Given this list of marker genes KCTD12, TJP3, LPXN, SHOX2, MAEA, RBFOX2, MBTPS2, SMTN, LTB4R, CXCL11, SCGB1A1, TIMP1, LPA, F3, BAP1, USP46, H4C2, SDHC, ABCD1, ZFP69B, SUSD5, ATRNL1, TBCD, DCBLD2, WASHC4, TOM1L2, IL5RA, STK35, PON3, EMC1 (ER membrane protein complex subunit 1), ZNF85, RPS12, ITPKB, OR2J2, WBP1L, RGS16, PPP1R2C, GSTT4, MAGED2, ATP6V1B1, NDUFA7, GLB1, SNX4, NIPBL, ANKRD7, MAD2L1, BRINP1, MUC5B, YWHAH-AS1 (NCBI Gene Id 25775), MID1, CCIN, ZMIZ1, CALCB, ELK3, BCLAF3, ZNF81, POLD3, ZNF460, TNNI2, VRK1, POT1, STAB1, FLT1, EPHB6, SNRPB, IDS, VAC14, EBAG9, NOL4, ABL1, CFHR2, CA2, ID3, CSF3R, LAMA3, MYBL2, SLC26A10P, LYRM1, MNAT1, IL5, RUNX3, ZFP36L1, SYT1, B3GAT2, PGF, PRR4, ZIC3, RBBP7, UQCRH, SEMA3E, DIXDC1, CHRNA6, PTPRN2, HLA-DQA1, GRIK1, GADD45G, TNNI3, S100A11, PPP1R12A, PNMT, HPGDS, PTPRT, NDRG4, NDUFB5, CYB561, MB, BCL6, EPB41L3, CD58, CPT1A, FOSL2, BARD1, TRIB2, SLA, RRAD, SUSD6, ASMT, SPARCL1, LCT, CRIPTO, NME6, GCNT2, H1-3 (NCBI Gene Id 3007), DKK1, TFDP1, MYO1B, ABAT, FDFT1, ART1, ENDOD1, CSNK2A2, NAALADL1, SMOX, CRISP3, RBM8A, RBFA, ELAVL4, ORC3, CLDN8, SORBS2, PDZK1, CDK5R2, PKP2, FKTN, NDRG1, DDN, SBF1, ATP1A3, MYL12B, PRSS12, H1-5, UNC93A, GJA4, TEP1, RBPJ, RTN2, H2AC11, DMPK, ST8SIA5, STRN, H1-2 (NCBI Gene Id 3006), SERPINB6, TENT4A, GRAMD4, NRIP1, ATP7B, SASH3, DDX6, SLC12A5, KIF3A, ZFR2, PLAGL1, OSBPL8, NTSR1, RBM17, TCF4, IMPG1, TNFRSF11B, CXCL5, LY6D, CD101, TGM3, WHAMM, PAFAH2, APBA3, KCNN3, EMILIN1, BHMT, EPHB2, SEMG1, GSTO1, PCSK1, PSEN1, FZD1, FCER1A, SEC13, DKK3 (dickkopf WNT signaling pathway inhibitor 3), here is a description of the gene set: species: Homo sapiens Genes down-regulated in BCL6 low follicular helper T cells versus naïve CD4 T cells. Human Gene Set: GSE24574_BCL6_LOW_TFH_VS_NAIVE_CD4_TCELL_DN from publication Kitano M, Moriyama S, Ando Y, Hikida M, Mori Y, Kurosaki T, Okada T (PMID 21636294) We found that a number of Tfh cells downmodulated BCL6 protein after their development, and we sought to compare the gene expression between BCL6-hi Tfh cells and BCL6-low Tfh cells.